The following is a description of a gene set: studied in species Homo sapiens Human Gene Set: GOMF_PHOSPHATIDIC_ACID_BINDING Binding to phosphatidic acid, any of a class of glycerol phosphate in which both the remaining hydroxyl groups of the glycerol moiety are esterified with fatty acids., and this is the list of marker genes: PITPNC1, COMMD1, PLEKHN1, GRAMD1B, MAPKAP1, SMPD3, PLTP, OPA1 (OPA1 mitochondrial dynamin like GTPase), MICALL1 (MICAL like 1), PITPNM1, UQCC3, CIDEA, RAPGEF6, GSDMD, PACSIN2, DEPTOR, PLCD1, MARK1, JPH2, CIDEC (NCBI Gene Id 63924), SESTD1, CIDEB, NRGN, RAPGEF2, ATP13A2